The following is a description of a gene set: species: Mus musculus Mouse Gene Set: BURTON_ADIPOGENESIS_3 During cellular differentiation and development, it is recognized that many complex molecular mechanisms as well as precise patterns of differentially expressed genes occur in directing precursor cells toward a given lineage. Using microarray-based technology, we examined gene expression across the course of 3T3-L1 adipocyte differentiation. Total cellular RNA was isolated at times 0, 2, 8, 16, 24, 48, and 96 h following treatment with either standard hormonal inducers of differentiation; insulin, dexamethasone, isobutylmethylxanthine (IDX), or IDX plus trichostatin A (TsA), a histone deacetylase inhibitor and potent adipogenic inhibitor. cRNA was synthesized from cellular RNA and hybridized to high density Affymetrix MG_U74Av2 microarray gene chips containing 12,488 cDNA/Expressed Sequence Tags (ESTs) probe sets. From the IDX-only treated cells, all probe sets that were either unchanged or differentially expressed less than 2-fold throughout differentiation with respect to time 0 preadipocytes were excluded from further analyses. This selection resulted in a net of 1686 transcripts, 859 were increased in expression, and 827 were decreased in expression at least 2-fold across differentiation. To focus in on genes that were more specific to differentiation, the same analysis was performed on IDX plus TsA-treated non-differentiating cells and all probe sets from the IDX-only group that exhibited similar expression profiles in the non-differentiating TsA-treated group were excluded leaving a total of 1016 transcripts that were regulated only under differentiating conditions. Six hundred and thirty-six of these transcripts were elevated at least 2-fold and 380 exhibited a decrease in expression relative to time 0 preadipocytes. This group of genes was further analyzed using hierarchical clustering and self-organizing maps and resulted in the identification of numerous genes not previously known to be regulated during adipocyte differentiation. Many of these genes may well represent novel adipogenic mediators and markers of adipogenesis. Strongly up-regulated at 16-24 h during differentiation of 3T3-L1 cells (fibroblast) into adipocytes. from publication Burton GR, Nagarajan R, Peterson CA, McGehee RE Jr (PMID 15033539), and this is the list of marker genes: Smc2, Ttk, Cdca8, Ezh2, Rrm1, Hmgb2, Abca1, Tfdp1, Fen1, Rfc5, Tubb6, Wnt4, Ccnb1, Il13ra1, Ilf2, Vcan, Cenpk, Kif4, Ccne2, Cx3cl1, Cdk1, Ccnf, Rad51ap1, Cdc6, Cstf2, D17H6S56E-5, Cdc45, Brca1, Asf1b, Kif20a, Ly6a, Slbp, Kif2c, Prl2c2, Mki67, Atf6b (activating transcription factor 6 beta), Man2a1 (mannosidase 2, alpha 1), Dlgap5 (DLG associated protein 5), Kif11, Osmr, H2ac4, Pnp, Mcm10, Impdh2, Cks2, Lrp5 (NCBI Gene Id 16973), Pcna, Topbp1, Cdc7, Dnmt1, Nup85, Incenp (NCBI Gene Id 98139), Dck, Birc5, Pola1, Bzw1, Pclaf, Ptgfr, Kpna2, Rad51, Phb2 (prohibitin 2), Kif22, Prc1 (protein regulator of cytokinesis 1), Rrm2, Tacc3, Tk1, Cdca7, Tyms, Prl2c3, Ifi211, Slco3a1, Hgf, Gas6, Rnaseh2c, Mcm4, Cdc20, Hells, Racgap1 (Rac GTPase-activating protein 1), Plk1, Tcf19, Cks1b, Ccnb2, E2f8, Ncaph, Mcm5, Aqp1, Fignl1, Klf5, Dtl, Nusap1, Lmo4, Mcm7, Mcm3, Adam8 (a disintegrin and metallopeptidase domain 8), Nasp, Csrp2, Dtymk, Prim1, Usp1 (ubiquitin specific peptidase 1), Bub1, Mcm2, Nqo1, Mad2l1, Aurka, Top2a